The following is a description of a gene set: Human Gene Set: HP_ABSENCE_OF_SECONDARY_SEX_CHARACTERISTICS Absence of secondary sex characteristics species: Homo sapiens No secondary sexual characteristics are present at puberty., and this is the list of marker genes: WWOX, POLA1, PROK2, KISS1R, CYP17A1, NR5A1, ZFPM2, HESX1, LHX4, HS6ST1, DUSP6, SOX9, FGF17, SOX3, KISS1, PROKR2, SPRY4, SRY, TAC3, GNRHR (NCBI Gene Id 2798), FGFR1 (fibroblast growth factor receptor 1), WT1, OTX2, CYP11A1, GNRH1, ESR1, FGF8, PROP1, POU1F1, MAP3K1, LEPR, LEP, NHLH2, NSMF, DHX37, GLI2 (NCBI Gene Id 50806), NR0B1, CHD7, VAMP7 (NCBI Gene Id 6845), WDR11, GATA4, TACR3, CYB5A, FOXA2